The following is a description of a gene set: Human Gene Set: KEGG_MEDICUS_PATHOGEN_HCMV_GH_TO_ITGA_B_RHOA_SIGNALING_PATHWAY HCMV gH to ITGA/B-RhoA signaling pathway. Pathway ID: N00394. Pathway type: Pathogen. Pathway class: nt06167 Human cytomegalovirus (HCMV). Pathway Definition from KEGG: UL75 -> (ITGAV+ITGB3) -> SRC -> RAC -| RHOA species: Homo sapiens, and this is the list of marker genes: RHOA, RAC2, ITGAV, RAC3 (Rac family small GTPase 3, NCBI Gene Id 5881), ITGB3, RAC1, SRC